The following is a description of a gene set: studied in species Homo sapiens Ca2+/CAM-CN signaling pathway. Pathway ID: N01647. Pathway type: Reference. Pathway class: nt06528 Calcium signaling. Pathway Definition from KEGG: Ca2+(cyto) -> CALM == CN -> NFAT Human Gene Set: KEGG_MEDICUS_REFERENCE_CA2_CAM_CN_SIGNALING_PATHWAY, and this is the list of marker genes: CALM3, PPP3R1, NFATC2, CALM1, NFATC1, PPP3R2, PPP3CC, CALM2, PPP3CB, PPP3CA (protein phosphatase 3 catalytic subunit alpha), NFATC4, NFATC3